Given this list of marker genes CDH23, PFKM, GADD45G, PPIF, EFHD2, METRNL, ERG28, LMNB1, SLC66A1, WIPI2, GPR83, SFRP2, CRYBB2, RNF149, TACR3, PRPS2, PLOD1, CTBS, TPST2, PGP, IFT22, PSEN2, GLRA4, DDAH2, GDPD3, MRTFA, CYB5R3 (cytochrome b5 reductase 3), TPCN1, IRAK1, CHKB, IFRD2, ARL4C, PLAU, JUND, BRS3, PRDM1, PHF3, CELA3B, SRRT, LIPF, GNB2, TUBA3C, KRT80, PGLYRP1, MAZ, FTL, UCK2, CLEC14A (NCBI Gene Id 161198), CCL25, TAC1, C1orf159, SYVN1, NRG4, PA2G4, RAB3C, MORC4, ASTN1, SEPTIN10, SGK1, HSP90AB1, P4HB, TRDN, SPTSSB, USP36, RASSF3, CYP24A1, FASLG, SMARCD2, PDIA4, GPR146, MAP4K1, PPOX, GNAI2, NAGS, ACTN4, VPS18, WAS, PMP22, SPR, DHODH, WNT2, TEX15, RDH16 (NCBI Gene Id 8608), METTL13, MYD88, TRIM2, IL23A, TMT1A, KPNA3, HS3ST3A1, PTBP1, NAA60, DBN1, NFKBIB, AQP4, UBE2E2, TNIP2, ARID5A, RAG1, CACNG6, ERN1, RASA4, MGAT1, SLC7A1, NPNT, IL10, RBM14, IFNG, PROM2, NFIC, TBX1, NFIA, IRF4, KLF9, SLC7A6, YRDC, EIF4G3, TNFRSF1B, CTNNA2, RSPH9, CASP7, SESN2, SGCE, CHCHD10, IL21R, SLC8A2, DNPH1, VPS41, ZFP64, FXR2, EIF4A1, POPDC3, SLC26A3, ARHGDIG, PCCB, PIP5K1B, WNK4, PACS2, TXNDC8, GEMIN8, IER5L, ITM2B, CSRP1, SOCS3 (suppressor of cytokine signaling 3), BPHL, KL, DZIP1, FTH1, MTCH1, HOXD13, ANXA8, CHST7, SLC6A12, CUEDC1, JUNB, STING1, LMO4, ABHD17A, FBXW9, ACO2, RNF166, KCNH1, IER2, SHKBP1, TUBB4B, ZNF593, CCDC85A (coiled-coil domain containing 85A), SH3BGRL2, FCGRT, GDF9, PTGER3, CCNE1 (cyclin E1), E2F1, KRT31, AMDHD1, PRSS58, PTOV1, FURIN, HLA-A, MGAT3, RNF19B, UCP2, AIM2, SLC48A1, HTR4, FAM169A, ADAM18, FGA, ATP8A2, PTP4A3, COTL1, RRAGA, SCRN3, EFHD1, KPNA1, BANP, PPP1R14C, ACTR8, TRIM3, TXNDC5, here is a description of the gene set: Genes up-regulated in T reg: wildtype versus ADORA2A. The adenosine 2A receptor (A2AR) is expressed on regulatory T cells (Tregs), but the functional significance is currently unknown. We compared the gene expression between wild-type (WT) and A2AR knockout (KO) Tregs and between WT Tregs treated with vehicle or a selective A2AR agonist. species: Homo sapiens from publication Kinsey GR, Huang L, Jaworska K, Khutsishvili K, Becker DA, Ye H, Lobo PI, Okusa MD (PMID 22835488) Human Gene Set: GSE34006_WT_VS_A2AR_KO_TREG_UP